The following is a description of a gene set: Human Gene Set: MIR6855_5P from publication Chen Y, Wang X (PMID 31504780) Genes predicted to be targets of miRBase v22 microRNA hsa-miR-6855-5p in miRDB v6.0 with MirTarget v4 prediction scores > 80 (high confidence targets). studied in species Homo sapiens, and this is the list of marker genes: NT5C2, GRIK5, PJA2, PCSK6, PATZ1, LTN1, PABIR3 (NCBI Gene Id 159091), COL27A1, DDIT4L, CASP3, RASAL2, DLGAP4 (NCBI Gene Id 22839), GUCA1B, LSM2, PPM1H, C5orf22, CAMTA1, POC1B, ARHGAP12, PPP6C, SHROOM4, PIGA, NBN, SUMO3, RIMS2, TCAF1, SHTN1, KPNA1, CACNB4, SPACA9, UNC119, DPP8 (NCBI Gene Id 54878), BRI3BP, IGLL5, SEMA6D, GPSM1, FBXL20, SEC14L2, ZNF470, PPP1R9B (protein phosphatase 1 regulatory subunit 9B), PPP1R3A (protein phosphatase 1 regulatory subunit 3A), ZNF345, HINFP, SLC38A4, DCP1B, CCDC82, AHI1, CLTA, CFAP210, CC2D1A, GUCD1 (guanylyl cyclase domain containing 1), FXN, RABL3, FRS2, SRPK1, MEOX1, HRH1 (histamine receptor H1), BCAM, USP44, IMPG1, HELZ, RORC, ETV1, TCF21, CLIP3, EPHA3, MEF2D